The following is a description of a gene set: Human Gene Set: HP_GASTROINTESTINAL_OBSTRUCTION studied in species Homo sapiens Gastrointestinal obstruction, and this is the list of marker genes: RET, CAVIN1, PALB2, SOX10, SDHA, GDNF, CTLA4, HLA-DPB1, EDNRB, ATP7A, PPOX, FOXP3, CTNNB1, GUCY2C, PALLD, SREBF1, SLC6A14, SEMA3D, HLA-DPA1, SLC26A9, BRCA1, WT1, FCGR2A, BRCA2, ERCC2, SDHB, TP53, MYH11, STK11, JAK2, CEACAM3, PDGFRA, EWSR1, HMOX1, GSTM3, MITF, SLC11A1, CD55, JAK3, NRTN, HFE, ECE1, NOTCH3, TGFB1, DCTN4, PRTN3, EDN3, KCNN4, TBCE, CALR, SLC18A3, F5, EXT1, CDKN2A, MVK, FAH, SDHD, MIF, SERPINA1, APC, SLC6A8, MYC, KIT, SMO, ABCD1, EDNRA (endothelin receptor type A), IL6, CLCA4, MTRFR, PDGFRB, EXT2, MNX1, SLC9A3, MEFV, CEACAM6, PTPN22, SMAD4, EFEMP1, ERBB3, NOD2, SDHC, SEMA3C, TNFRSF1A, STX1A, RABL3, TTC7A, ARPC5, HMBS, ERBB2, CFTR, KRAS, KIF26A, GCLC